The following is a description of a gene set: The directed movement of chloride ions from one side of an epithelium to the other. Mouse Gene Set: GOBP_TRANSEPITHELIAL_CHLORIDE_TRANSPORT studied in species Mus musculus, and this is the list of marker genes: Clcnka, Slc12a2, Ostm1, Slc26a6, P2ry6, P2ry4, Clcnkb, Clcn7 (NCBI Gene Id 28069), Cftr, Best1